The following is a description of a gene set: from publication Gavish A, Tyler M, Greenwald AC, Hoefflin R, Simkin D, Tschernichovsky R, Galili Darnell N, Somech E, Barbolin C, Antman T, Kovarsky D, Barrett T, Gonzalez Castro LN, Halder D, Chanoch-Myers R, Laffy J, Mints M, Wider A, Tal R, Spitzer A, Hara T, Raitses-Gurevich M, Stossel C, Golan T, Tirosh A, Suvà ML, Puram SV, Tirosh I (PMID 37258682) In this study, an extensive analysis was conducted to define meta-programs (MPs) capturing intra-tumor heterogeneity across a spectrum of tumor types. The approach utilized non-negative matrix factorization (NMF) to analyze each cell type separately within individual tumor samples. This involved the analysis of malignant cells, macrophages, fibroblasts, endothelial cells, epithelial cells, T-cells, and B-cells. NMF was executed with varying parameter values (K=4, 5, 6, 7, 8, 9), thereby generating 39 programs for each cell type per sample. Each NMF program was summarized by the top genes based on NMF coefficients.\nRobust MPs were then delineated for each cell type using a set of stringent criteria, including recurrence within the same tumor, similarity to programs in other tumors, and non-redundancy within a tumor. Subsequently, these robust NMF programs were clustered (per cell type) based on Jaccard similarity, leading to the identification of MPs associated with each cell type.\nTo enhance the quality of the MPs, a refinement steps were undertaken, involving the removal of MPs suspected of reflecting low-quality data (with an overrepresentation of ribosomal proteins or mitochondrial-encoded genes), single-study inclusion, or similarity to miss-annotated cell types. studied in species Homo sapiens Human Gene Set: GAVISH_3CA_METAPROGRAM_EPITHELIAL_EPI3 Genes upregulated in subsets of cells of a given type within various tumors, and this is the list of marker genes: KRT6C, TUBA1C, FGFBP1, KRT16, KLHL21, KDM6B, LAMC2, TGM1, DDX21, TNFRSF12A, PHLDA2, HBEGF, S100A9, NOP16, CDKN1A, GJB2, PTPRE, ANXA1, ECM1 (extracellular matrix protein 1), S100A2, S100A8, HAS3, MAP7D1, KRT6B, VEGFA, EGLN3, AREG, GJB3, NPPB, SOWAHC, ODC1, NDUFA4L2, BNIP3, SMOX, LAMA3, SERPINB2, PHLDA1, FSCN1, KRT6A, ZC3H12A, LY6D, INHBA, FOSL1, CALD1, NDRG1, EPHA2, TUBB6, LYPD3, KRT17, IER3